The following is a description of a gene set: from publication Chen Y, Wang X (PMID 31504780) Human Gene Set: MIR7705 Genes predicted to be targets of miRBase v22 microRNA hsa-miR-7705 in miRDB v6.0 with MirTarget v4 prediction scores > 80 (high confidence targets). studied in species Homo sapiens, and this is the list of marker genes: CSDE1 (NCBI Gene Id 7812), ZC3H12B, PCDH20, HINT3, ERRFI1, TNFSF13B, KCNT2, KANSL3, DNAJC27, FAM174A, RMND5A, THAP2, SDCBP, MVB12B, RYBP, PCLO, BTG2, IL6ST, HYCC2, ANO10, RGS17, PHIP, CAPRIN1, IL22, FBN2, CHMP4C, ZC3H12C, METAP2, STRADB, GCNA, PMPCB, RERE, FAT3, ANKRD46, POF1B, FMOD, ZNF268, CSMD3, ST3GAL1, CRLF1, HCN4, DDX17 (NCBI Gene Id 10521), SPAG1, HEXIM1, PPP4R4, SEPTIN14, MSX1, ADRA2B, RPA3, LIMCH1